The following is a description of a gene set: Genes predicted to be targets of miRBase v22 microRNA mmu_miR_3535 in miRDB v6.0 with MirTarget v4 prediction scores > 80 (high confidence targets). species: Mus musculus from publication Chen Y, Wang X (PMID 31504780) Mouse Gene Set: MIR_3535, and this is the list of marker genes: Serpinb3b, Pira2, Esco2, Ppp2r2a, Fndc4, Peli2, C5ar1, Faah, Col4a5, Epas1, Brdt, Gm6878, Lce3e, Zfp1, Slitrk1, Mta3, Llcfc1, Acat1, Abca8a, Egfl6, Rpl15, Bivm, Kcnab1, Bdnf, Ryr2, Acer3, Mmachc, Zbtb5, Fnip1, Gjb3, Bcor, Phip, H2-Q10, Mbnl2, Pcdh9, Tmem132c, Serpinb3c, Zfp120, Stmn1, Retreg3, Srsf10, Slc5a12, Serpinb3a, Zfp345, Phb1, Mamdc2, Pira12, Zfp609, Mb21d2, Slc41a1